Given this list of marker genes ALOX15, ALOX15B, GPX2, GPX1, PTGS2, GPX4, here is a description of the gene set: The 15-eicosatetraenoates: 15-hydroperoxy-eicosatetraenoate (15-HpETE), 15-hydroxyeicosatetraenoate (15-HETE) and 15-oxo-eicosatetraenoate (15-oxoETE) are formed after the initial step of arachidonate oxidation by the arachidonate 15-lipoxygenases (ALOX15 and ALOX15B). part of: Arachidonate metabolism Reactome Pathway: Synthesis of 15-eicosatetraenoic acid derivatives studied in species Homo sapiens